Given this list of marker genes HMG20B, CDC25C, SP1, BLM (NCBI Gene Id 641), NFKBIA, BACH1, STAT5A, CCNA2, AR, CCNE1, RB1, SMC1A, RAD51, ELK1, NPM1, TUBG1, SMAD3, NBN, HDAC2, CCND1, CDK4, RBBP7, MRE11, BARD1, BRCA2, EMSY, MSH2, KPNA2, MDC1, TP53, MCM3, FHL2, BUB1B, E2F4, CDK2, PLK1 (polo like kinase 1), AURKA, CHEK2, DHX9, RAD9A, PLK3, RPA2, CHEK1, ATF1, JUNB, CREBBP, PRKDC, FANCD2, NUFIP1, EP300, MLH1, JAK2, JAK1, MED1, CTBP1, ATR, RBBP4 (RB binding protein 4, chromatin remodeling factor), RELA, KAT2B, BCCIP, RFC2, FLNA, MDM2, BRAP, RPA1, CSNK2A1, CCNB1, CDK1, ESR1, MYC, ABL1, FANCA, MSH6, RFC4, ATM, NMI, SEM1, TP53BP1, TERF2, ACACA, NELFB, CDC25A, H2AX, RAD50, ZNF350, FANCG, RPA3, SMARCA4, XRCC6, RBBP8, AKT1, CLSPN (claspin), HDAC1, STAT1, PEX5, BAP1, RFC1, TERF1, E2F1, MAP2K3, LMO4, here is a description of the gene set: Many cancer-associated genes remain to be identified to clarify the underlying molecular mechanisms of cancer susceptibility and progression. Better understanding is also required of how mutations in cancer genes affect their products in the context of complex cellular networks. Here we have used a network modeling strategy to identify genes potentially associated with higher risk of breast cancer. Starting with four known genes encoding tumor suppressors of breast cancer, we combined gene expression profiling with functional genomic and proteomic (or 'omic') data from various species to generate a network containing genes linked by 866 potential functional associations. This network shows higher connectivity than expected by chance, suggesting that its components function in biologically related pathways. One of the components of the network is HMMR, encoding a centrosome subunit, for which we demonstrate previously unknown functional associations with the breast cancer-associated gene BRCA1. Two case-control studies of incident breast cancer indicate that the HMMR locus is associated with higher risk of breast cancer in humans. Our network modeling strategy should be useful for the discovery of additional cancer-associated genes. from publication Pujana MA, Han JD, Starita LM, Stevens KN, Tewari M, Ahn JS, Rennert G, Moreno V, Kirchhoff T, Gold B, Assmann V, Elshamy WM, Rual JF, Levine D, Rozek LS, Gelman RS, Gunsalus KC, Greenberg RA, Sobhian B, Bertin N, Venkatesan K, Ayivi-Guedehoussou N, Solé X, Hernández P, Lázaro C, Nathanson KL, Weber BL, Cusick ME, Hill DE, Offit K, Livingston DM, Gruber SB, Parvin JD, Vidal M (PMID 17922014) Genes constituting the LIT-Int network of proteins interacting with breast cancer reference proteins BRCA1, BRCA2, ATM, and CHEK2; the interactions were manually curated from the literature. studied in species Homo sapiens Human Gene Set: PUJANA_BREAST_CANCER_LIT_INT_NETWORK